Given this list of marker genes TOB1, EAF2, DENND6A-DT, VARS2, C19orf47, BTAF1, PPA1, TIMELESS, SSBP1, COQ10B, DOCK8-AS2, CREBRF, SRGAP1, RFX2, ATP1A3, IDH1, PMM2, KCTD9, UNC50, RANBP3, NDUFB10, PKNOX1, LRRC23, MARCHF6, RNU6-103P, RTKN2, SNORA14B, RUSC1, CNOT4, GPATCH2L, SKIDA1, CCHCR1, CNST, SNX10, MEST, LIPG, EIF2B1, CENPA, HRCT1, DDX5, AGAP3, REXO2, ENSG00000283175, DYNC2I1, MARCHF6-DT, RPS7P6, RPLP2, EXOSC3, SLC35D1, PABPN1 (poly(A) binding protein nuclear 1), MET, EPHB4, KANSL3, CCDC9 (NCBI Gene Id 26093), RPA2, TAF13, PLBD1-AS1, DRG1, GPN2, NR2F6, ZNF528-AS1, MTPAP, SNORA48, CDNF, TUBA1B-AS1, CNIH3, WTAP, GET1, HNRNPA0, CDCA7L, EMC6, PPP4R3B, SLC3A2, TGDS, TMEM250, SLC35A4, GORASP2, PRR14L, CDCA2, CLN5, TMCC3, EIF4H (NCBI Gene Id 94573), DNAJC2, SAP30, VPS13A, KIF11, EFTUD2, ATP2B4, VPS33A, ATF4, C16orf87, HAL, HSD17B6, RETREG2, CCDC28A, SEMA6A, LENG9, RNU6-92P, MACROD2, FAIM, DLGAP1-AS2, AKT1, MVB12A, CCDC146, AVPI1, DDX54, CFAP61, PSMB9, MISFA, HMGB1, LEKR1, MTG1, TTLL4, WDTC1, SNX5, UCKL1, SF3B6, PPP2R3C (NCBI Gene Id 55012), NRBF2, TOP6BL, VTRNA1-2, BMAL2, TMEM232, RRS1-DT, STAMBP, POLR1HASP, CHEK1, PCGF1, P3H1, UVSSA, ZNF815P, TTC12, APAF1, NUP50, TP53, POLR3A, CRYM, YWHAQ, MNS1, ACSS2, SEPTIN7-DT, ZNF584, DENND6A, EIF3L, DCAF6, PARP3, RAD18, MOB4, COA5, CAMK2G-AS1, LTO1, PIDD1, UQCRQ, RRP15 (NCBI Gene Id 57241), EPM2A-DT, BORCS8, EEF1A1, CFAP96, HNRNPK, MPV17, LINC02651, POLI, NHLRC3, CRYZL1, PPAT, PARK7, EPN1, TOB1-AS1, NDUFB3, EHBP1, NR1H3, CIC, HEXIM1, NBPF1, H2AX, C4orf33, MRPS21P8, SCLT1, NXF1, WDR48, NBEAL1, HSP90AA1, SAE1, BRD2, FAF2, CCN1, GSAP, FAM185BP, RPL26, ATP6V0E2, HSPA14 (NCBI Gene Id 51182), LLGL2, RNASEH1, FZD1, FAM151B-DT, POP5, EXOC8, TUFM, TP53BP1, TIGD4, RPL5, TSACC, SQSTM1, PPIEL, RHEBL1, LRRC26 (NCBI Gene Id 414321), BCKDHB, CAMTA2, RPS12, HSDL2, AARSD1, EME1, PIK3IP1-DT, RNGTT, STXBP4, CD44, DEPDC1B, TMED7-TICAM2, RNASEH2C, PON3, RSRP1, SNX15, MCMBP, TCTA, ROPN1L-AS1, USP11, ANKRD54, SMCR8, EGLN1, AK6, SNORD115-35, NEBL, TRAPPC6A, MGME1, ZC3H10, ARMC10, LARS1, SLC4A8, NOL10 (NCBI Gene Id 80085), THRIL, SEC23IP, COG5, SCIRT, CDC14A, PRH1, ZSWIM3, IPO7, MRTO4, POC5, MRPS18C, CNNM3, PRR4, ARID4B, GNRH2, FAM151B, CLIC3, TMEM116, MIA2, ASCC1, METTL16, WASHC5, KLC2, AFTPH-DT, SPRY1, SNORD115-11, SEPTIN7, TAF9, IGF2BP3, TCEA2, VTRNA2-1, ADCY6, PPP2R5B, RNF123, SAP30BP, C2CD5, TMEM256-PLSCR3, ERCC4, AKT1S1, MIOS-DT, CCT4, HEXA, CMSS1, MKNK1, POMGNT1, EIF4A1, SRRM2-AS1, ZNF397, CA5BP1, IKBIP, PSTK, RASL11B, EEF1A1P18, ARRDC4, MIR1275, MECOM, ZNF414, HSD17B2, NUP88 (NCBI Gene Id 4927), ERV3-1, LINC01810, HECTD4, OAS3, INTS13, TOP3A, CAV2, RRS1, OXSR1, NSMCE2, PAWRP1, PHF12, FBXL13, AKAP13, OXLD1, ZNF616, PRMT7, IMPDH2, SUMF2, RAPGEF6, RPS13, ARL6IP1, RGMB, NOSIP, RAB40C, ZNF292, APTR, MDM2, ZFAND2A-DT, MVK (mevalonate kinase), SUPT16H, SFR1, MAST1, HGS, HOXC-AS1, PIPOX, ZC3H14, AGO3, SYMPK, HSPB6, PCSK5, WDR20, PRORP, ZNF425 (NCBI Gene Id 347684), APH1A, HINFP, MEAF6, STXBP5-AS1, DNAJC21, GEMIN2, ERGIC1, TANK-AS1, PIK3IP1, PECR, NAGK, KNL1, NDUFA2, NRXN3, FAM210A, SERP1, NSMCE3, CRKL, NEK10, ZNF786, RPSA, SPRYD7, PACSIN3, SPC24, ZNF25-DT, GGPS1, BET1, HNRNPUL1, CCDC168, NOX5, SMARCA2, SRRM2, UBE2W, ATN1, TMEM169, MAP3K10, KHDC4, ADAP1, RNF11P1, PPP1R16B, FAAP24, CTDSPL2-DT, ITGB4, SPAG1, SMTN, FGD4, CREM, TSPAN31, MAPKAPK5-AS1, STAM2, ERCC6, TAAR2, GGA3, DXO, PSMA4, C1orf43, RNF19A, ZBED5-AS1, CDCA8, MIR4635, NAPA, E4F1, METTL17, FLII, CRIPT, ATG3, TRAPPC13, SAP30-DT, FBXO30, HAX1, PROSER3, TMCO6, SHFL, NADK2, LINC02122, KANSL1, SLC39A13, OASL, MYOM2, ITSN1, SEH1L, MPHOSPH8, MDGA1, FITM2, TUFT1, CDK4, DHX8, ZNF627, DYNC1I2, LRP6, GCDH, DIABLO, SLC27A1, VRK2, RGMB-AS1, MTERF1, DCDC1, RECQL5, HDLBP, ST6GALNAC2, SAP30L-AS1, ARHGEF10, FIGNL1, TRAV8-7, SLC25A53, RNF31, ZNF444, SPCS2, MTMR12, STARD7, FAM222B, NRAV, PIK3R2, RBM34, ZNF639, REX1BD, EXOC7, PSMA2, PLK2 (NCBI Gene Id 10769), THBS3, WNT10A, ING5, UQCRC1, TMED7, ENSG00000237813, CENPJ, PLCD1, RNASEH1-DT, MYPOP, RPAIN, PIP4K2A, MIR615, LINC00471, PSME2, RUSC1-AS1, SDR39U1, PSMC2, HELQ, USP36, MAPK8IP2, SIX5, ASNS, EML6, RAB3A (RAB3A, member RAS oncogene family), GTF2H3, IARS2, HLCS, LINC01664, NAT10, DENND2D, TRIM59, CKMT2-AS1, CEP89, CASP6, YJU2B, GAK, ELOF1, CNTD1, S100P, ARSJ, FAM187A, POLH, ANTXR2, BCL2L2, ESPL1, SLC39A6, CCNT2, ZBTB17, PROSER1, MYC, ATP6V0E2-AS1 (NCBI Gene Id 401431), PPAN, RPL24, EMC1, AKTIP, PSMA3, UQCC6, USP9X, HILPDA, HOXA-AS2, ROMO1, JRKL, YAP1, DELE1, EHD1, PIMREG, ZFAND2A, MTA2, TPM1, HSD17B4, EMC4, NARF, ATF2, B3GAT3, ARL6IP6, MICU2, SNORD25, TMEM202-AS1, NEURL4, ARHGAP39, CENATAC-DT, TEFM, B3GALT6, TMEM14C, C3, SRSF10, DTNB, CLDN6, COG8, HNRNPA3P7, RBM33-DT, TNR, XPOT, TMEM161B, FAM219A, GADD45A, CRNKL1, UEVLD, CYFIP1, RTCA, CNOT3, NPRL2, FGFR1OP2, MRPS7, SNHG5, GMIP, IDH3B-DT, TTC19, MFSD3, TAF10, DYNLL1, BLTP1, ZBED5, NUDCD3, MZF1-AS1, CCDC103, NDST2, MIR6814, RANGAP1, SHLD3, USP45, SLC35A5, LINC02960, ZNF346, IDH1-AS1, ANXA2R, LOXL2, EXD2, PLEC, GATAD2A, TRIM37, C16orf95-DT, SNHG14, MST1, CAP1, HAUS3, SLC44A2, TANK, KRTCAP3, RCE1, CFAP119, COPB2, INKA2-AS1, LINC02585, PHF3 (NCBI Gene Id 23469), GALNT16-AS1, LINC00524, RHOC, SLC7A6OS, NUDT5, RPL13P5, SNAPC5 (NCBI Gene Id 10302), ATG5, MAGI2-AS3, UFSP2, HEXA-AS1, PARP10 (NCBI Gene Id 84875), PPAN-P2RY11, CELSR3, CEP170B, CCDC91, APBB3, MCM3AP, MIR4276, DNAI1, CISD3, CMTR2 (NCBI Gene Id 55783), IFTAP, DDOST, PPP4R3B-DT, NIF3L1, TP53I3, MAP1A, MAML3, RAD1, JADE1, NOL3, TIMM50, SNORD26, OXTR, MRPL27, PRMT2, ESYT1, NINL, BAG6, SPAG16 (NCBI Gene Id 79582), NUP50-DT, FLVCR2, FAM228B, TTC14 (tetratricopeptide repeat domain 14), TRIM23, COMMD1, AMACR, PGD (NCBI Gene Id 5226), NDUFC1, SEL1L2, TCIRG1, SPICE1, ROPN1L, EIF2A, TAX1BP3, HPSE, MIA2-AS1, PRIM1, PDCD6, RANBP3-DT, SNHG1, GNAI2, PPM1K, AFTPH, HMGB3P22, DUS4L, DDX18 (NCBI Gene Id 8886), CREBZF, CHCHD3, DDX50, U2AF2, STK19, METTL6, APP, ADGRF3, TUBD1, RLF, RRP9, PRDM1, NFRKB, ETF1, CCDC82, HEXIM2, GCHFR, RGL2, FEZ2, PRMT5, WDTC1-DT, HAP1, SPAG16-DT, MRPL32, CACNA2D1, PMAIP1, STEAP2-AS1, TPT1-AS1, CLSTN1, SNORD30, ZNF843, SNHG30 (small nucleolar RNA host gene 30), NAA30, DTYMK, SELENOK, CDC42SE1, WRAP53, BTF3L4, PRMT5-DT, KPNA2, FBRSL1, RNU6-327P, RETREG3, TOX2, IQCB1, EPOR, ALDH2, SIN3A, MGAT1, TBK1 (TANK binding kinase 1), CUL5, COA1, MIR3621, AIMP1, DNAJC28, PYGB, PDCD6IP, HNRNPH3, MRPS9, ACP2, CERS5, SEC24A, SEM1, PLD3, CCND3, SUN1, PRPF31, FBXO41 (NCBI Gene Id 150727), HOMER1 (homer scaffold protein 1), CEP164, UIMC1, FOXA3, PUF60, TMEM186, ZNF446 (NCBI Gene Id 55663), EIF2D, PTBP3, SUCO, RNVU1-4, CXXC1, CHD2, SYN2, FEM1A, UBE2T, PISD, SDHD (NCBI Gene Id 91899), FBXO2, ANAPC15, GRIN2A, SEC1P, CHD1 (chromodomain helicase DNA binding protein 1), CCNT2-AS1 (NCBI Gene Id 100129961), THORLNC, XRCC5, MYCN, PPP1R12A, CNOT8, SPRTN, WRAP73, OPTN, POU2F1, KANK1, C2orf42, RAB14, WEE2-AS1, WDFY2, EWSAT1, TUBA1B, PPP2R2D, RAPGEF3, CES2, C10orf88 (NCBI Gene Id 80007, chromosome 10 open reading frame 88), ENSG00000263280, CLDN16, SLC25A36, OTULIN-DT, ZBTB26, SELENOI, LINC02361, NIP7, CEP95, RSBN1L, RHOA, PPOX, SCAND1, TOMM20, TIMM8B, NANOS3, ZNF232, SNORD101, SNHG6, NDRG1, C1orf50, MIR6828, SAP30L, TFPT, IK, CCDC28A-AS1, ATG16L2, SUPT3H, TUBA4A, DNAJC24, CCDC183, SLC25A51 (NCBI Gene Id 92014), CIPC, SNRPE, BCL2L2-PABPN1, RTCA-AS1, TTC14-DT, HYCC2, RHPN2, ENSG00000261335, RAB3IL1, RNU6-1236P, ZBTB3, CCDC125, MDP1, KIFBP, PRPF40A, DBP, COQ5, PCDH1, POLR2A, TRNAU1AP, COPB2-DT, MARCHF3 (NCBI Gene Id 153277), TFB2M, SPTY2D1, RUSC2 (NCBI Gene Id 9853), TMEM11-DT, NAA15, MAPKAPK5, MRPL45, MIR4512, HAPSTR1, ALKBH2, RPL30P11, FBRS, SLC12A9, UBE3C, UPP1, DCP1B, DBNL, PHF14, ENSAP1, MOB2, UNG, PIM1, SP4, HENMT1, DENND5B-AS1, LINC02901, SKA3, CC2D1B (coiled-coil and C2 domain containing 1B), SYNGR4, RAD17, LZTR1, ANAPC16 (NCBI Gene Id 119504), WDR90, NUB1, CNPPD1, TMEM161B-DT, CENATAC, ATXN2L, CA5B, ACTMAP, LMO7, C10orf120, RPS3, EIF4A2, ARL4A, MIR933, TAS2R14, OTULIN, PTK2B, INTS2, ASL, TTYH1, FBXW4 (NCBI Gene Id 6468), FLAD1, GHR, CTDP1, MYG1, RAB35, MRPL33 (NCBI Gene Id 9553), ENSG00000260830 (novel transcript, antisense to CHD8 and SUPT16H), RCBTB2, GPRC5C, TIA1, CSNK1G1, TENT5C-DT, UBE2M, MTX1, NARF-AS2, LARP1, DTWD1, BTBD8, IGHD2-8, BDP1, SAR1B, SEMA4B, NEBL-AS1, TMEM143 (NCBI Gene Id 55260), MIR3613, FAM227B, ZNF117 (zinc finger protein 117), POLN, ABCC8, SNORD15A, PPM1K-DT, TXNDC12, RTN4, CYB5B, RTF2, ORC5, ABHD10, ZFP41, PCYT1A, CIDEA, MIR3125, EFNA4 (ephrin A4), TCF19, PLEKHA6, TMEM121B, FAM220A, MRM1, TMEM54, SRGAP3, RNMT, GTPBP8, ITGB8, EFNA4-EFNA3, C2, AIRIM, RNU4-2, TRAPPC9, MALINC1, RAG1, ZC3HAV1, UBAP2L, GDAP1, FLT4, TOR1AIP1 (torsin 1A interacting protein 1), G3BP1, SDHAF4, CCT3, SLC12A7, UBE2Q1, ACOT8, NUDCD1, BLOC1S3 (biogenesis of lysosomal organelles complex 1 subunit 3), PLD6, VPS8, ASCC3, ZNHIT2, CTDSPL2, DTX4, CLCN3, NDFIP2, NDUFAF6, TXNDC15 (NCBI Gene Id 79770), LINC01168, PFKL, SLC35E3, CLIC4, SNX10-AS1, FAM98C, FAXDC2, POLG2, RASA1, SARS2, CYB561D2, PRR12, RNVU1-22, B9D2, MAGI2 (NCBI Gene Id 9863), MRPS27, CDC123, MPC2, INKA2, NPM2, CHCHD2P6, SLC16A13, CCDC137, DPYD, SEPTIN2, WDR12, TBCK, GDF9, ANXA2R-AS1, TCAIM, C15orf61, DEPDC4, PNISR, ENSG00000272008, SH3PXD2A-AS1, ANKRD33BP1, PIGF, MRPL57, NUP214, PKN2, PPP1R37, NFYB, HEXIM2-AS1, IFT172, IQCH-AS1, SSBP2, CTPS1, RNF111, BRIX1, TTC12-DT (NCBI Gene Id 124902814), GARS1, ZSWIM7, SPESP1, INKA1, LCE3A, SNORD22, SERF2, TNRC6C, TRIM25, LETM2, TMOD3, GPATCH8, XRRA1, PGAM5, VPS13C-DT, MDFI, SEC31A, SLC25A46, SNRPA, MED18, PTPN6, RN7SL832P, SLC35F6, DMC1, MIR495, ZNF584-DT, PGBD2 (NCBI Gene Id 267002), RPS6KB1, CANX (NCBI Gene Id 821), SH2B1, SERPINB5, LPXN, DARS1-AS1, EVI5, BMP6, ENY2, RNF40, TULP3, ARMC2, CIAO2B, ZBTB4, SNORD118, YBEY, LINC-PINT, UCK1, MAP2K3, SCYL2, UBE2L6 (ubiquitin conjugating enzyme E2 L6), MIGA2, ARB2A, PMPCB, FRMD5, CUEDC1, LETM1, USPL1, TRPT1, ARIH1, AXIN1, CENPM, ESYT2, TMEM11, PSMA5, TBC1D17 (NCBI Gene Id 79735), MALSU1, SSPOP, MRPS16, PPIL3, LBHD1, PELO-AS1, TUBG1, DCUN1D4, JAK2, ARFIP1, MRPS12, STOML2, ELP2, CNBD2, here is a description of the gene set: studied in species Homo sapiens Genes containing one or more binding sites for (ID2) in their promoter regions (TSS -1000,+100 bp) as identified by GTRD version 20.06 ChIP-seq harmonization. Human Gene Set: ID2_TARGET_GENES from publication Yevshin I, Sharipov R, Kolmykov S, Kondrakhin Y, Kolpakov F (PMID 30445619)